Given this list of marker genes DTL, KIFC1 (NCBI Gene Id 95229), DLGAP5, MYBL2, KNL1, TK1, CDK1, ZWINT, STMN1, PRR11, TICRR, NUSAP1, KIF23, MKI67, TOP2A, KIF18B, APOBEC3B, KIF15, CDC25A, TYMS (thymidylate synthetase), KIF14, CCNE1, KIF20A, ESCO2, CCNA2, CDCA8, PIMREG, SAPCD2, MCM4, BUB1B, CDCA2, NCAPG, GTSE1, KIF18A, PKMYT1, BIRC5, CENPF, TROAP, E2F7, ASF1B, CKAP2L, NCAPH, POLQ, BUB1, ESPL1, PAQR4, CENPE, UBE2C, AURKB, CDC20 (cell division cycle 20), TPX2, FAM111B, CENPM, MCM10, BRCA2, CDCA5, UBE2T, RRM2, HJURP, E2F2, ASPM, ANLN, KIF2C, E2F1, CENPU, PRPF31 (pre-mRNA processing factor 31), E2F8, SKA3, here is a description of the gene set: Genes up-regulated in natural killer cell 3d vs 0d in adults (18-49) after exposure to inactivated monovalent influenza A/Indonesia/05/2005 H5N1 split-virus vaccine, time point 3D, administered i.m. from publication Howard LM, Hoek KL, Goll JB, Samir P, Galassie A, Allos TM, Niu X, Gordy LE, Creech CB, Prasad N, Jensen TL, Hill H, Levy SE, Joyce S, Link AJ, Edwards KM (PMID 28099485) studied in species Homo sapiens Human Gene Set: HOWARD_NK_CELL_INACT_MONOV_INFLUENZA_A_INDONESIA_05_2005_H5N1_AGE_18_49YO_3DY_UP BACKGROUND: Vaccine development for influenza A/H5N1 is an important public health priority, but H5N1 vaccines are less immunogenic than seasonal influenza vaccines. Adjuvant System 03 (AS03) markedly enhances immune responses to H5N1 vaccine antigens, but the underlying molecular mechanisms are incompletely understood. OBJECTIVE: We compared the safety (primary endpoint), immunogenicity (secondary), gene expression (tertiary) and cytokine responses (exploratory) between AS03-adjuvanted and unadjuvanted inactivated split-virus H5N1 influenza vaccines. In a double-blinded clinical trial, we randomized twenty adults aged 18-49 to receive two doses of either AS03-adjuvanted (n = 10) or unadjuvanted (n = 10) H5N1 vaccine 28 days apart. We used a systems biology approach to characterize and correlate changes in serum cytokines, antibody titers, and gene expression levels in six immune cell types at 1, 3, 7, and 28 days after the first vaccination. RESULTS: Both vaccines were well-tolerated. Nine of 10 subjects in the adjuvanted group and 0/10 in the unadjuvanted group exhibited seroprotection (hemagglutination inhibition antibody titer > 1:40) at day 56. Within 24 hours of AS03-adjuvanted vaccination, increased serum levels of IL-6 and IP-10 were noted. Interferon signaling and antigen processing and presentation-related gene responses were induced in dendritic cells, monocytes, and neutrophils. Upregulation of MHC class II antigen presentation-related genes was seen in neutrophils. Three days after AS03-adjuvanted vaccine, upregulation of genes involved in cell cycle and division was detected in NK cells and correlated with serum levels of IP-10. Early upregulation of interferon signaling-related genes was also found to predict seroprotection 56 days after first vaccination. CONCLUSIONS: Using this cell-based systems approach, novel mechanisms of action for AS03-adjuvanted pandemic influenza vaccination were observed. TRIAL: ClinicalTrials.gov NCT01573312.